The following is a description of a gene set: part of: Hh mutants abrogate ligand secretion Hh signaling is required for a number of developmental processes, and mutations that disrupt the normal processing and biogenesis of Hh ligand can result in neonatal abnormalities. SHH is one of a number of genes that have been associated with the congenital disorder holoprosencephaly, which causes abnormalities in brain and craniofacial development. SHH variants associated with the condition affect the autocatalytic processing of the precursor and dramatically impair the production of the secreted active Hh-Np, abrogating signaling. species: Homo sapiens Reactome Pathway: Hh mutants are degraded by ERAD, and this is the list of marker genes: UBC, PSMA4, PSMB5, PSMD1, VCP, PSMB2, PSMA6, OS9, PSMC6, SHH, RPS27A, PSMB1, SEL1L, PSMA5, PSMA7, PSMD8, PSMC1, PSMA1, PSMC2, PSMA2, ERLEC1 (endoplasmic reticulum lectin 1), PSMD6, PSMB6, PSMD3, SEM1, PSMD14, UBA52, UBB, SYVN1, PSMC3, PSMD13 (proteasome 26S subunit, non-ATPase 13), PSMD7, PSMD12, PSMB4, ADRM1 (ADRM1 26S proteasome ubiquitin receptor), PSMB7, DERL2, PSMC4, PSMB3, PSMC5, PSMA3, PSMD2, PSMD11